Given this list of marker genes KCNG3, CCRL2, ICAM1, ADHFE1, ACSL1, UBE2L6, RELB, FBXL3, GBP3, DYRK2, NUPR1, IGSF6, CXCL11, MMP10, CCL4, TNFAIP2, PELI1, GPR18, MARCKSL1, MTDH, CD69, HIVEP3, RAB11FIP1 (NCBI Gene Id 80223), CNOT7, IFIH1, TTC39C, NT5C3A, SLC16A10, ARL5C, PPM1A (NCBI Gene Id 5494), STIM2, CSF1, IL15, NXPE3, ADGRF1, CXCL1, PLIN1, ZUP1, TNFSF4, MTMR14, HIVEP2, DDHD1, RSBN1, NCK1, SHC2, PTTG1, INTS12, IFT57, NOD2, JAK2, PRPF38A, FAS, PIK3CA, LTV1, SAP30, SVBP, PTPRJ, GPR85, CTRL (chymotrypsin like), ZHX2, ARID5B, HIPK3, FRMPD4 (FERM and PDZ domain containing 4), PLXNA4, PAM, FLNB, TANK, ZFAND5, RIPK2, IL27, IRF1, ADGRG6, PALS1, PIM1, BIRC2, DUSP16, CD83, NFKBIB, TRIM21 (tripartite motif containing 21), ISG15, PIK3R6, CDC42EP2, DNM3, PSMB10, ACOT9, MIR155, IFITM5, STAP1, HCAR2, TM9SF4 (transmembrane 9 superfamily member 4), PTGS2, ICOSLG, BTG2, OSGIN2, GBP5, TMEM168, PLSCR1, NFKB1, LCP2, NOS2, YJU2, REPS1, RNF2, STX11, KLF3, RTN2, ESF1, N4BP1, IL1A, BRI3, RNF14, CASP4, ATF3, PSMD10, BIRC3, TRAF1, ZC3H12C, LMO4, VCAM1, ARHGEF3, A1CF, CALCR, NAALADL2, ITGB8, RASGEF1B, OAF, PCDH7 (NCBI Gene Id 90855), SOD2, ABTB2, SLC2A6, ZC3H15, CLEC5A, CD40, TAGAP, RGL1, TNFAIP3, SP110, IFNB1, AHR, CFLAR, IL34, SOCS3 (suppressor of cytokine signaling 3), HEATR6, FOXP1, TAF7, CISH, RASGRP1, COP1 (NCBI Gene Id 64326), TNIP1, MALT1, SOCS7, FNBP1L, PTGES, REL, ABI1 (abl interactor 1), TPBG, PLAGL2, EDN1, AMPD3, MARCKS, NAB1, PLEK, SOCS1, MMP13, MAPKAPK2, MX2, TAL2, ZC3HAV1 (NCBI Gene Id 79678), MAP3K8, ZBTB5, here is a description of the gene set: Genes down-regulated in macrophages: untreated versus LPS. from publication Foster SL, Hargreaves DC, Medzhitov R (PMID 17538624) The inflammatory response initiated by microbial products signaling through Toll-like receptors (TLRs) of the innate immune system is essential for host defense against infection. Because inflammation can be harmful to host tissues, the innate response is highly regulated. Negative regulation of TLR4, the receptor for bacterial lipopolysaccharide (LPS), results in LPS tolerance, defined as hyporesponsiveness to repeated stimulation with LPS. LPS tolerance is thought to protect the host from excessive inflammation by turning off TLR4 signal, which then shuts down TLR-induced genes. However, TLR signaling induces hundreds of genes with very different functions. We reasoned that genes with different functions should have different requirements for regulation. Specifically, genes encoding proinflammatory mediators should be transiently inactivated to limit tissue damage, while genes encoding antimicrobial effectors, which directly target pathogens, should remain inducible in tolerant cells to protect the host from infection. Using an in vitro system of LPS tolerance in macrophages, here we show that TLR-induced genes may indeed be divided into two distinct categories based on their functions and regulatory requirements. Further, we show these distinct groups are regulated by gene-specific, and not signal-specific mechanisms. species: Homo sapiens Human Gene Set: GSE7348_UNSTIM_VS_LPS_STIM_MACROPHAGE_DN